The following is a description of a gene set: Reactome Pathway: Response to metal ions electronically inferred by orthology from the curated human pathway species: Mus musculus part of: Cellular responses to stimuli This event has been computationally inferred from an event that has been demonstrated in another species.<p>The inference is based on the homology mapping from PANTHER. Briefly, reactions for which all involved PhysicalEntities (in input, output and catalyst) have a mapped orthologue/paralogue (for complexes at least 75% of components must have a mapping) are inferred to the other species., and this is the list of marker genes: Mt2, Mt3